The following is a description of a gene set: The chemical reactions and pathways resulting in the breakdown of a macromolecule, any molecule of high relative molecular mass, the structure of which essentially comprises the multiple repetition of units derived, actually or conceptually, from molecules of low relative molecular mass. studied in species Homo sapiens Human Gene Set: GOBP_MACROMOLECULE_CATABOLIC_PROCESS, and this is the list of marker genes: PRAMEF26, MIR9-1, MIR20A, TRAF5, TRIM3, TIPARP, MYCBP2, CIRBP, MIR423, CDC20, TF, YTHDF3, DTX4, CDC20B, RLIM, NQO1, KBTBD3, SNCA (synuclein alpha), UBE2K, NEMF, HERC3, MIR665, MIR137, IFI27, FBXO8, ANG, NORAD, RHOBTB3, PRKCG, MIR200C, BFAR, CCNF (cyclin F), MIR564, ERN1, PPP1CA, MIR193A, DFFB, SLFN13 (schlafen family member 13), UBE2G1, BAG2, RNF123, PABPC1, AMFR, UBQLN1, ZCCHC17, RDX, KIF14, MIR519D, SNX5, CDC26, DCP2, MTPAP, PLK3, NPLOC4 (NPL4 homolog, ubiquitin recognition factor), CHMP5, EEF1A1, SLC17A9, DAB2IP, HEXA, ZCCHC8, RHBDD3, VPS4A, FBH1, UBE2L5, RSPRY1, FASTK, SPG11, EXOSC5, USP28, NKD2, TSPAN5, TRAF7, CNOT1, RNF168, ZNF268, FBXO7, RNF19B, MIR23A, SEL1L2, PDCD6IP, PYGB (NCBI Gene Id 5834), TAF15, NT5C3B, UPF3B, HOTTIP (HOXA distal transcript antisense RNA), CACNG7, PCYOX1, PSME1, SGSM3, SEC22B (NCBI Gene Id 9554), MIR149, PSMA7, MIR151A, RNH1, RFPL1, UBE2W, WDR45B, RC3H2, FBXL6, RNF103, TRIM38, SIRT6, AGO2, PGLYRP2, IGF2BP3, FBXL5, EIF3E, SNX25, CLN6, PDE12, USP9X, PTPN3, CNOT10 (NCBI Gene Id 25904), PPP1R3B, OS9, SPATA18, ASCC3, FBXO2, HNRNPA0, SEM1, MIR190B, CANX, HECW1, FZR1, DIS3L2, CUL2, ASCC2, ERN2, WIPI1, MIR142, CSNK1D, NICOL1, AREL1, AOAH, MIR26B, TMEM199, FBXO17, LARP1B, NOTCH1, PRAMEF12, ENC1, ERLIN2, CTSC, AXIN1, MIR483, USP33, UBR1, MIR302A, IDE, FASTKD3, AKT1, PABIR1, IDS, MIR340, PRSS16, DCP1B, PHKA1, UCHL5, AGAP2, VCP, CLN8, NUDT12, TTC5, GPLD1, C4BPA, CASP8, ECSCR, MIR365A (NCBI Gene Id 100126355), MIRLET7A1, DEDD, OAS2, DHX9, ECPAS, TOB1, GID8, ATG2A, CECR2, FBXO6, TP53INP2, DCPS, HFE, PPP2R5C, FBXW11, DKC1, CLPX, RAB12, MAEA (NCBI Gene Id 10296), DTL, CNOT3, KLHDC1, RBM47, CCDC47, UBE2S, MAPK9, EXOSC3, MIRLET7E, YTHDF2, IFT80, SMURF1, APP, SETMAR, OGT, KLHL10, AMER1, CSDE1, SUMO1, UBAC2, RNF180, DNASE2B, STAB2, TRIM67, MYLIP, EPM2A, CHMP4BP1, RNF41, LARP4B, RNF121, CTSW, FBXW4, MIR19B1, P2RX7, RNF20, CSNK2A2, PPP2R3A, DVL1, PRAMEF19, SOCS2 (NCBI Gene Id 8835), ZRANB1 (zinc finger RANBP2-type containing 1), MAGEF1, MIR133A1, PGM2, VPS13A (NCBI Gene Id 23230), UBE2E1, PSME3IP1, CHEK2, STYX, ATG2B, DFFA, MANBA, CTRL, TPP1, MAD2L2, GSK3A, ALAD, DNASE1L1, UBL7, INTS6, CHIA, PJA1, GPC1, MOV10, TMEM259, MVB12B, NANOS3, SOCS5, TENT2, RBM24, KHSRP, HYAL1, ANAPC1, RNF5, AKIRIN2, RNF170, LIN28B, TMEM132A, LYVE1, UBE2N, TNFAIP1, FBXW7, RNF139, CREBRF, AGO4, PTPN23, PML, DDI2, USP17L24, CST7, BAG5, NEDD4L, OGA, NEU2, STAM2, UBE4B, DACT1, SPSB2, UFSP2, SQSTM1, KCTD2, PSMB8, KCTD6, KLHL35, LRRC75A, RNF144B (NCBI Gene Id 255488), COPS3, PRMT6, MIR204 (microRNA 204), INTS1, RNF43, EDEM3, WIPI2, FXR2, POP1 (POP1 homolog, ribonuclease P/MRP subunit), JKAMP, UBXN4, ASB1, KLHL23, SVIP, ARIH2, ATP13A2, IRGQ, TARDBP, NGLY1, ADRA2A, CEACAM1, APPBP2, ZNRF4, GET4, SOCS7, PISD, HERC6, LAMP3, CPEB3, KLHL25, MIR29B1, ARK2C, UBA6, MALAT1, SMG5, XBP1 (X-box binding protein 1), TGFB1, OAZ3, KLHL38, PYGM, TREX1, WDR81, SH3RF3, MAGOH, CLU, EEF1A2 (NCBI Gene Id 6669), TESK1, PSME3, HMGCR, VIM, ROCK1, KCTD10, NMNAT1, TMEM9, INTS2, CNOT7, PSMD13, PSMC1, DNAJB9, CEMIP, ZMPSTE24, AGTPBP1, RBM10, MIR106B, HNRNPU, GAN, ABHD17A, GABARAPL1, UBE3B, PHKG2, HM13, TRDMT1, OAZ2 (ornithine decarboxylase antizyme 2), TNFRSF1B, UBR4, ZFAND2B, SNX12, PATL2, PSMA4, DDIT3, PCSK9, DERL3, INTS3, TRAF4, METTL16, PAN2, TRIM39, LRP1, MIR373, CDC34, MIR210, APOC2, MIR223, TENT5B, RNF25, GABARAPL2, CELA2A, TENT5A, KLHL11, ENDOG, PDCL3, BMAL1, EIF4A3, PSMA2, TNFAIP3, TRIR, PRKCA, CENATAC, INS, CTSA, ATG7, VIP, TRIB1, DNAAF4, UBXN2B, DCST1 (DC-STAMP domain containing 1), KLHL41, UBE2L3, MIR24-1, SGSH, EGFR, ADRM1, PUM1, RNASET2, PKP3, CUL1, ABHD17C, SECISBP2, RNF26, MIR495, ABHD10, FHIT, KLHL2, SYVN1, SMAD7, SPSB3, MIR543, MARCHF2, MIR491, TIMP1 (TIMP metallopeptidase inhibitor 1), ARID5A, IER3, TMTC3, PABPN1L, CNOT9, CCAR1, PANO1, FBXO3, SH3BGRL, FBXO22, USP44, KLHL40, BTRC, RNF144A, PRKN, PRAMEF1, INTS9, PRAME, DNASE1L3, DXO, DDA1, SPOP, PINK1, UFD1, HNRNPAB, PBK, CBFA2T3, TTC3, YBX3, CTSF, PSMB5, PSME2, MARCHF7, ACR, MIR520C, KCTD21, MIR708, MAN1A2, IFNG, UBE2J2, CTNNB1, CSNK1A1, INTS8, GRIN2C, PYGL, GLMN, RBBP6, CACUL1, MIR663A, FBXL15, KBTBD2, EDC3, PAIP1, DDI1, HNRNPD, DNA2, HECW2, SH3GLB1, FOXL2, OAZ1, UBE3A, TRIM25 (tripartite motif containing 25), PELI1, GRN, ELAVL1, BCAP31, GUSB (NCBI Gene Id 2990), MAN1C1, DERL2, INTS4, LONRF2, RNF187, SHH, A1CF, RNASEH1, RNF128, ELAC2, PNRC1, DAZ4, MIR320A, KLHL12, PUM2, KLHL17, CAPN3, RNF111, SKIC3, TRIB2, IPP, PSMD4, INTS7, MAGEC2, SIAH2, ANAPC16, IL17RA, EPHA4, POLR2G, IKBKE, FBXO10, PSMA5, BECN1, KBTBD12, SAYSD1, UBQLN4, MRTO4, CASC3, RNF148, MVB12A, TMF1, CASP3, USP13, UVRAG, TNKS1BP1, MIR199B, USP17L6P, LYG2, FMR1, TUT4, SNX1, STBD1, RNF11, UBXN6, MIR130A, CHFR, NSF, GLB1, UBE2C, UBXN10, MMP12, PRKACA, CPA1, MIRLET7B, F8A2, PSMC6, EGLN2, UBE2J1, KLHL24, LATS1, PKD1, TCIRG1, UBXN8, DICER1, FBXO44, KCTD5, EFNA1, NEDD8 (NEDD8 ubiquitin like modifier), ADAMTS13, CHMP1A, ANAPC15, PSMB6, RNF4, HSPA1B, BCAS2, SIDT2, VPS4B, CHMP7, APOE, GDNF, MEX3D, TRIP4, HERC2, GBA1, DAZL, CHMP1B, SNX9, TBL1X, SMARCC1, UBE2U, FAM8A1, CSNK2B, RNF125, RBM7, RB1CC1, QKI, WDR77, VPS37A, IGF2BP1, FUS, GSK3B, LTN1, METTL14, MIR103B1, MIR200B, HAMP, MIRLET7C, CAV1, SIRT1 (NCBI Gene Id 23411), LSM5, PIWIL1, GPRASP1, PRAMEF20, PGPEP1, MIR342, RAD23A, ZNF598, KLHDC2, SH3D19, EXOG, FMN2, BIRC2, UHRF1, TRIM45, TMEM168, KBTBD8, THRAP3, TTC36, CDKN2A, ARMC5, NCBP2, SORL1, ZSWIM8, UPF1, PABPC4, TOLLIP, SNRNP70, AFG2B, PMAIP1, ZFP36L2, DCAF11, EXOSC6, MIR497, FYN, RIC1, MIR100 (microRNA 100), NUB1, SUMO2, NOTUM, PARN, PEX12, GTPBP1, CDK5, GIGYF2, PHAX, FBXO9, AQP11, HSP90AA1, KIF16B, RNF215, GPC3, TIMP2, C4BPB, PSMB2, RNFT1, FBXO27, NANOS2, NHLRC3, RMND5B, CTSZ, FBXO39 (NCBI Gene Id 162517), MALT1, LONP1 (NCBI Gene Id 9361), RBM46, RNF114, KBTBD7, MAN1A1, MAPKAPK2, PSMB1, XRN2, TRIB3, WDR45, MIR145, NOP53, NKD1, RNF213, CHIT1, SOCS6, SUFU, PSMD12, FASTKD2, TREM2, ANKZF1, MYD88, TOPORS, DEDD2, ERI1, HECTD3, CDC23 (NCBI Gene Id 8697), MTA1, NEAT1, GCLC (NCBI Gene Id 2729), MIR125B1, SNX3, DDB1, GGA1, IL33, LIAT1, MDM2, RNF19A, MIR93, PRAMEF7, CDK5RAP3, RMND5A, INTS5, TGFB1I1, TOM1L1, HTRA2, TMX1, RNASE3, ARRDC1, INTS12, NFE2L1 (NFE2 like bZIP transcription factor 1), INTS13, BBS7, TRIM32, ALKBH5, PSMD6, TUT1, FBXW8, UBE2D2, EXOSC2, FBXO4, PARK7, ROCK2, NRDE2, ADCY10, KLHL8, BTK, WWP2 (NCBI Gene Id 116013), ISG20, SGTA, ARAF, SYNCRIP, PPP1R11, ETF1, RNF150, CAPN2, HERC5, ANAPC2, AMN1, NDFIP2, USP14, CDC27, APOBEC1, UBE2B, PCYOX1L, DAZ2, ARMC8, UBD, STAM, ABCA2, PSMD2, PFKM, UBA1, VPS35, PTK2B, FBXO38, TBRG4, GRIN2A, FASTKD5, RIPK1, FEN1, CHMP4A, NBDY, SCGB1A1, RAB7A, SNF8, PRAMEF22, SHARPIN, LYPLA1, TNRC6A, RNF186, MDM4, HACE1, SF3B3, RNASE2, PSEN1 (NCBI Gene Id 5663), CBLB, HGS, PRAMEF4, RNF130, CSNK2A1, UBXN11, BECN2, NDFIP1, GIPC1, IL6, ATM, ITCH, PGLYRP3, KLHL4, METTL1, OIP5-AS1, BRSK2, BTG2, CLOCK, MIR30B, FXR1, SMG8, CUL9, FOXRED2, FBXO21, DENND3, TRIM9, MIR424, TMUB1, FBXL3, PGLYRP1, MIR20B, IDUA, MIR146A (NCBI Gene Id 406938), HSP90AB1, RPS7, TBL1XR1, FBXL7, PRAMEF15, ZYG11B, KLHL5, UPF2, ST14 (NCBI Gene Id 6768), PRKCD, LRRK2, LRPPRC, ADGRB1, HERC4 (NCBI Gene Id 63907), HSPA1A, ZC3H12A, UBXN1, PYHIN1, UBQLN2, ODC1, PSMD9, GZMB, PITHD1, ELANE, LYPLA2, UBQLNL, PYM1, DBR1, ARRB1, FEM1A, UBE2A, PRAMEF18, CNOT2, LSM7, OPHN1, DAB2, L3MBTL3, RNASE6, CTBS, OXA1L, KLHL28, PRAMEF33, MAGEA2B (MAGE family member A2B), PSMD10, PTEN, KCTD17, VPS36, AURKA, DERL1, TLK2, TMEM126A, MIR203A, SMG9, FOXF2, TIRAP, MTOR, RBM8A, HYAL3, PSMC4, RILP, RYBP, SUPV3L1, CEBPA, BAG6, EXOSC10, GPX1, MIR885, PIN1, NPM1, LGMN, XRN1, ZFP36L1, MMP2, FBXL22, RCN3, ASB11, EXOSC8, RNF14, AGL, EXOSC1, ASB5, NDUFA13, CHMP2A, NSUN2, NELL1, APC2, APOB, WWP1, MTREX, NANOS1, LSM4, NEDD4, NOCT, ZHX2, EDEM2, HYAL2, MIR181D, TRIM72, MIR181B1, REXO4, PCNP, FBXL20, AFG3L2, UBE2D1, CTSS, CARHSP1 (NCBI Gene Id 23589), EZR, DNASE1, GSPT1, GATA5, UBQLN3, DDRGK1, LNPEP, UBE2L6 (ubiquitin conjugating enzyme E2 L6), MIR27B (NCBI Gene Id 407019), DPP7, ASB9, NHLRC1, APAF1, CSNK2A3 (casein kinase 2 alpha 3), ARK2N, QRICH2, CALR, SMG7, KCTD13, SOX17, TREX2, RNF217, ADAMTS7 (ADAM metallopeptidase with thrombospondin type 1 motif 7), ZDHHC2, ZC3H12D, ZC3HAV1, MIR655, TRIM58, TOR1A, FAU, UBE2D4, MIR106A, HPSE, PAN3, ATF6, CNOT8, ZCCHC7, FBXO46, PRAMEF14, PIWIL2, GSPT2, GID4, PSMD3, PSME4, PPT1, ARIH1, KLHDC10, UBR7, BNIP3L, CHI3L1, DIS3, PDLIM2, NOS2, KCMF1, LARP1, FAM76B, APEX1, UBE2H, G6PC1, MIR1-1, MIR329-1, SPSB1, BNIP3, KBTBD6, SAMD4A, UPF3A (NCBI Gene Id 95832), EXOSC4, NSFL1C, ATP5IF1, UTP25, NUDT16L1, MMP14, MIR211, DMAC2, DISC1, KLHL30 (NCBI Gene Id 377007), ATRAID, PRAMEF13, CCDC115, TIMP4 (NCBI Gene Id 7079), DNAJC3, HMGB1, RHBDF1, AGO1, MIR302C, DCAF12, RPL23, TRNT1, SPSB4, CUL5, ZC3H14 (NCBI Gene Id 79882), AMBRA1, CUL4A, PRAMEF8, PHF20L1, CALCR, CLN3, VPS28, ATG12, DET1, MIR130B, FBXL13, GIT1, SKIC2, FEM1C, CHMP4B, UBR2, MIDN, HERPUD1, MIR485, MMP3, GTPBP2, CELA1, SH3RF2, KLF1, USP7, ANAPC4, RNASEH2C, C1QBP, TRAF2, SLC11A1, FTO, GABARAP, ZER1, MAGEA2, CALR3, CMA1, CD2AP, YOD1, ATG3, FASTKD1, OVGP1, FEM1B, SMG6, TRIM13, WNT5A, RPL5 (NCBI Gene Id 90045), UBXN7, HMMR, APC, RNF175, SNX33, RNF34 (ring finger protein 34), NSUN4, UBE2D3, PJA2, CBLC, RNF7, SEL1L, ANKRD9, CRBN (cereblon), PRAMEF9, RNF185, PNPT1, PCBP4, PSMC2, TRIP12, PATL1, ECRG4, GAA, USP8, RAD23B, STX5, PPP2CB, MIR486-1, CHMP3, MTMR2, ANAPC10, RNF166, F8A1, ERCC8, COMMD1, VPS37D, LPCAT1, LSM14B, SLFN12, YTHDF1, NUDT15, PELO, TENT4B, PSMD11, MIR96, KLHL22, ZNRF2, MIR181C, FAF2 (Fas associated factor family member 2), AUP1, VPS25, UBA7, CHI3L2, SIAH3 (NCBI Gene Id 283514), RNF10, KLHL20, RPL11, HBS1L, SMURF2, DNM3OS, HUWE1, HDAC6, RACK1, LSM1, MIR19A, ASB2, IL10, LIPA, CTSD, MIR140, PRPF19, HSP90B1, RNF8, ANAPC7, NAF1, MIR181A2, RNF216, TENT5D, CPN1, CHMP6, KLHL42 (kelch like family member 42), MIR18A, PSMB4 (NCBI Gene Id 5692), SENP1, IL1B, PSMB11, EDEM1, ATXN3L (NCBI Gene Id 92552), KLHL21, AGO3, TUT7, ADAMTS4, SERPINB12, DNAJB12, ZPR1, MIR135B, RBX1, MIR562, LRP2, HSF1, NCBP1, PSMA8, ELAVL4, ZC3H4, IREB2, OSBPL7, ADAM8, DNASE2, CCIN, ISG15, STUB1, MIR519A1, ANAPC11, AZIN2, FBXO24, NFE2L2, MIR128-1, GNS, CUL3, STT3B, NAGLU, MIR98, UBE3C, HSPA8, YME1L1, ATG5, PSMF1 (proteasome inhibitor subunit 1), PSMC3, MIR34B, RNF40, LDLR (NCBI Gene Id 3949), CTSV, SELENOS, IGF2BP2, ANAPC13, CHMP2B, PIK3R4, UCHL1, CUL4B, UBE2I, CIDEA, BARD1, CYP51A1, RNASEH2B, ERLIN1, RNF13, DNASE1L2, FBXO48, GRSF1, CLGN, BRINP1, BOLL, LIN28A, CUL7, SND1, EXOSC7, MME, MIR191, TNFSF12, CTSB, CNOT6, MAD2L1, FBXO31, CAV3, GNA12, BAG3, USP26, ZAR1, CNOT4, TRIM24, VPS37C, TSG101, FBXO11, EXT1, RGMA, FURIN, KLHL1, GFAP (NCBI Gene Id 2670), LRSAM1, RNF133 (ring finger protein 133), PSMA1, CTSL, SLC6A17, CNOT6L, TRIM31, FGF2, WNT10B, KLHDC3, LSM2, CLN5, OTUD7A, RHBDD1, METTL3, FBXL2, SLFN14, RFFL, ERLEC1, UBE2R2, UBE3D, HSPBP1, RNF115, PRAMEF2, LAMP2, EDC4, UBR3, KLHL18, CSDC2, NR1D1, BAX (BCL2 associated X, apoptosis regulator), PLK2, MLH1, MIR125A, XIST, TMUB2, UBAP1L, CLPP, LYG1, AXIN2, RNASEH2A, MIR206, PNLDC1, TRIM26, PTPN1, DND1 (NCBI Gene Id 373863), TENT5C, FBXL19, CTSO, USP38, SERPINE2, KLHL6, MIR27A, ZFP36, RHBDD2, PSMD7 (NCBI Gene Id 5713), SMG1, GZMA, RBCK1, CELF1 (CUGBP Elav-like family member 1), FAP, VPS11 (VPS11 core subunit of CORVET and HOPS complexes), MSN, SDF2L1, UBR5, SIRT2, MIR212, PKP1, PSMB10, TENT4A, ADAM10, CTIF, VHL, MGAT3, E2F1, CBL, RNF122, RCHY1, CD44, FBXO45, XPO1, SH3RF1, TSPAN17, USE1, PEX10, TMEM129, PSMC5, MTM1, ZNF418, DDX49, PNRC2, PSMD14, DTX3L, MIR501, PIAS4, PCBP2, YBX1, ATXN3, DCP1A, UBA52, AZIN1, DCAF1, OMA1 (NCBI Gene Id 115209), PRAMEF25, OTUD7B, TRIM2, DNAJB2, RPGR, INTS15, UBXN2A, ABHD17B, SPOPL, HNRNPC, CD81, RNF126, DAZ1, CDC16, EPG5, CAMLG, FBXL17, PRAMEF17, DAZ3, NEURL3, TSPAN15 (tetraspanin 15), RNF6, ELOB, MIR625, SLC6A7, CAPN1, F8A3, PIAS1, WDR82, WFS1, CASP7, KAT5, KLHL15, SIAH1, SLIRP, TRIM21, PGLYRP4, PSMA6, RGP1, MIR517C, FBXL12, SSB, PLAA, MIR544A, FBXL4, CTSK, PRAMEF10, HECTD1, PRICKLE1, DAOA, RELA, RNPS1, PPP1R8, ANGEL2, PHB1, MAN1B1, COP1, DESI1, EGF, TNRC6B, KEAP1, PPP1R3D (protein phosphatase 1 regulatory subunit 3D), SAMD4B, FBXW5, TRAF3IP2 (TRAF3 interacting protein 2), INTS10 (integrator complex subunit 10), MARCHF6, LSM6, SOX9, LONP2, TRPC4AP, INTS11, MMP20, DHX34, RNF149, SMAD3, RC3H1, MAGOHB, IKBKG, TMEM106B, PAQR3, USP19, TNRC6C, SRSF1, MEIOC, UBE2Z, MIR185, FBXL14, DIS3L, SOCS4, UBAP1, TRIM71, USP25, CEMIP2, DNAJC10, ELOC, ANAPC5, HGSNAT, CDH1, CAPRIN1, PSMA3, EIF3H, SMAD4, RBM38, PSMB7, PLEKHN1, MIR517A, FOXO1, PRAMEF27, MGAM, UMOD, KLHL7, HYAL4, ZFAND2A, SERBP1, MAP1A, TIMP3, DCAF13, DHX36, TMEM67, NTAN1, FBLL1, CHMP4C, AMBP, TBX21, UBL4A, FAF1, PTK2, EXOSC9, SKP1 (NCBI Gene Id 6500), AFG1L, KCNE2, HEXB, MFSD8, FBXL18, CST3, MKRN2, ADAM9, TRIM40, PRAMEF6, PSMD8, ANXA2, RIDA, USP5, INTS14, CPA2, DDX5 (NCBI Gene Id 1655), NCCRP1, TRIM28, VGLL4, LAPTM4B (NCBI Gene Id 55353), HSPA5, GTSF1, PRAMEF5, PRR5L, MIR214, PPP2R1A, MIR337, N4BP1, PLK1, MIB1, MIR608, FBXL16, UBB, CNOT11, LAPTM5, ATE1, PACSIN3, UFL1, FLNA, NUPR1, AGAP3, ZNRF1, PPP2CA, AGBL4, UBE2G2, EIF4ENIF1, CTSH, PRAMEF11, CCDC22, WAC, MIR326, RNF146, BAP1, KLHL3, NEU4, TAF1, VPS54, WNT1, UCHL3, CSNK1E, CDK2, SPAM1, MIR195, RNASEL, CDKN1B, NBAS, UBC, WWTR1, CCAR2, WDR91, IVNS1ABP, FAM83D, GGA3, WDR26, PSMB9, RBM33, MIR192, KLHL29, LRIG2, TAF9 (NCBI Gene Id 6880), MIR4286 (microRNA 4286), MUS81, ZC3H18, ADAMTS12, HIPK2, SKP2, VPS37B, ARHGAP5-AS1, SEC61B, ZNRF3, ANKIB1, LNX1, NRDC, AP5Z1, IRAK3, SKIC8, TNF, RNF145, RNF167, RNFT2, PSMD1, PSMB3, MAPK14, NUDT16, UBE4A, RPS27A (ribosomal protein S27a), ARRB2